Given this list of marker genes MCFD2, SOS1, LMAN1, F8, VWF, here is a description of the gene set: Reduced factor VIII activity Reduced activity of coagulation factor VIII. Factor VIII (fVIII) is a cofactor in the intrinsic clotting cascade that is activated to fVIIIa in the presence of minute quantities of thrombin. fVIIIa acts as a receptor, for factors IXa and X. Human Gene Set: HP_REDUCED_FACTOR_VIII_ACTIVITY studied in species Homo sapiens